The following is a description of a gene set: Human Gene Set: MIR6883_3P Genes predicted to be targets of miRBase v22 microRNA hsa-miR-6883-3p in miRDB v6.0 with MirTarget v4 prediction scores > 80 (high confidence targets). from publication Chen Y, Wang X (PMID 31504780) studied in species Homo sapiens, and this is the list of marker genes: UBE2K, MEX3D, HECA, COG6, TMEM47, RBL2 (RB transcriptional corepressor like 2), ABHD5 (abhydrolase domain containing 5, lysophosphatidic acid acyltransferase), CRBN (NCBI Gene Id 51185), CHD7, NCAPG2, EDRF1, SEC22B, SUMF1, PPL, FIGN, MEAK7, ARFGEF1, TENT4B, CDYL2, SUZ12, COP1, GADL1, PAQR3, RASAL2, SELENOI, NCKAP1, SRP72, FBXL20, GRIN2A, OXR1, PTBP2, STAT1, HDAC8, MYT1L, PLEKHG6, ZFX, OIT3, GID8, NRG2, GPR37, LATS2 (NCBI Gene Id 95108), AMMECR1, ARF6, FBXO38, CHRM2, POU2F1, AIPL1, ZNF875, DCUN1D5, RBL1 (RB transcriptional corepressor like 1), CAMK2N1, FAM98B, ARL1, RRN3, IFT57, CHD1L, ABHD10, OR51E2, LRP2, ARCN1